Given this list of marker genes Catsper3, Catsperb, Kcnu1, Catsper1, Catsperg1, Catsper4, Hvcn1, here is a description of the gene set: electronically inferred by orthology from the curated human pathway studied in species Mus musculus This event has been computationally inferred from an event that has been demonstrated in another species.<p>The inference is based on the homology mapping from PANTHER. Briefly, reactions for which all involved PhysicalEntities (in input, output and catalyst) have a mapped orthologue/paralogue (for complexes at least 75% of components must have a mapping) are inferred to the other species. Reactome Pathway: Sperm Motility And Taxes part of: Fertilization